Given this list of marker genes NECTIN4, PVR, CADM3, CADM1, NECTIN3, NECTIN1, NECTIN2, here is a description of the gene set: Reactome Pathway: Nectin/Necl  trans heterodimerization Nectins and Nectin-like molecules (Necls) also undergo trans-heterophilic interactions to interact with other nectin or Necl family members. Besides these trans interactions among nectins and nectin-like family members, trans-homophilic interactions have also been described between nectins or Necls with other immunoglobulin-superfamily members like CD96, CD226 and CRTAM. It should be noted that some of these interactions might not exist in epithelial cell-cell contacts but may occur in other cell-cell adhesion systems. part of: Adherens junctions interactions species: Homo sapiens